Given this list of marker genes MIR129-1, ITGA4, MIR21, MIR150, NRARP, GHRL, MDK, SP1, MIR20B, TGFBR1, MIR132, MIR126, COL4A3, MIR503, MEF2C, FGF2, SLC39A9, PLCG1, MIR152, GHSR, DBH, MIR499A, PROK1, MIR495, MIR27A, PPARG, MIR98, MIR424, ALDH1A2, HMGB1, FLT1, FGFR1, IGF2, APLN, MIR29C, MIR200C, PDPK1, ADAM17, MIR15B, MIR329-1, MIR30E, MIR492, MIR487B, MIR133B, SIRT6, MIR135B, MIR130A, MIR24-1, MIR29A, MIR34A, MIR193A, MIR30B, AKT3, CCL2, STAT3 (signal transducer and activator of transcription 3), here is a description of the gene set: Human Gene Set: GOBP_VASCULAR_ENDOTHELIAL_CELL_PROLIFERATION species: Homo sapiens The multiplication or reproduction of blood vessel endothelial cells, resulting in the expansion of a cell population.